The following is a description of a gene set: mouse primary BMDCs were stimulated with tlr ligands and gene expression changes were profiled on Affymetrix arrays Human Gene Set: GSE17721_POLYIC_VS_CPG_6H_BMDC_UP species: Homo sapiens Genes up-regulated in comparison of dendritic cells (DC) stimulated with poly(I:C) (TLR3 agonist) at 6 h versus DC cells stimulated with CpG DNA (TLR9 agonist) at 6 h. from publication Amit I, Garber M, Chevrier N, Leite AP, Donner Y, Eisenhaure T, Guttman M, Grenier JK, Li W, Zuk O, Schubert LA, Birditt B, Shay T, Goren A, Zhang X, Smith Z, Deering R, McDonald RC, Cabili M, Bernstein BE, Rinn JL, Meissner A, Root DE, Hacohen N, Regev A (PMID 19729616), and this is the list of marker genes: CEP350, MTARC2, ASB7, AHCYL2, MVP, FUNDC1, OTULINL, RNF128, SEC22A, DNAJC12, BRINP1, TALDO1, BCL2L14, XRN1, WDFY1, FRYL, N4BP3, INA (NCBI Gene Id 9118), POLB, DNAJC8, CWC22, NUP42, UCK2, HMBS, RAB3IP, RPS16, CBX2, GNA13, KIF1B, INSIG2, MEF2C, HOMER1, SPEN, RGS14, MOCOS, EPB41, CNTROB, ATP8A1, MTMR4, PLEKHA2, SNAPIN, LMNA, CUL4B, OAS2, TNRC6A, MCM7, STXBP1, RRAGC, MYOF, FAM53C, SLC25A3, MIA2 (MIA SH3 domain ER export factor 2), TBCE, RPL12, MCM6, ARGLU1, PHKB (NCBI Gene Id 5257), BRWD3, LRRC61, TIMM8A, PIP5K1C, MORC3, COX7A2L (NCBI Gene Id 9167), RAB12, SDF2, CTDSP2, ATXN7, DNMT3A, SESN3, GPSM2, SRRD, SPATA19, CORO1C, VGLL4 (vestigial like family member 4), TMEM268, MED11, CHIC2, FGR, LRRC40, ECE2, FLI1, CDKN1B, RAP2C, ARHGEF7, HERPUD2, LEF1, SERINC3, HSDL2, TOB1, PARP8, HTR3A, MAGI3, ASF1A, NECTIN4, SPSB1, COMT, BLTP3B (NCBI Gene Id 23074), DAPP1, KDF1, ITCH, HAUS4, SUN2, REEP5, PLCG2, CDA, RP2 (NCBI Gene Id 6102), TMEM37, PALS2, STOM, LHX2 (NCBI Gene Id 9355), LAMTOR1, TSPAN14, MAFK, RFC1, PTCH2, XPO1, RIN2, UGDH, PLEKHF2, SYNJ2BP, METTL8, CD2AP, BRDT, FANCA, PSMG1, SEMA3F, MIA3, KDM5B, PHLDB1, TREX1, PNRC1, SPHK1, USP15, ULK1, GRN, IRAK4, CSNK1D, UQCRC2, MRC1, CLIP1, JRK, BIRC2, MTBP, ACIN1 (NCBI Gene Id 22985), NUP93, RASAL2, CTSC, EI24, BCL9, NFIL3, ZC3H18, PGLYRP1, MAP2K3, FCGR1A (NCBI Gene Id 50698), NAGA, ECHDC1, ANKIB1, AVL9 (NCBI Gene Id 23080), PTCH1, AFTPH, PSIP1, ACVR1, BBS9, CHST15, AAK1, ACADM, RREB1, SP7, SNX2, CASP8 (caspase 8), EN1, BMPR1A, SCAMP2, HEXB, MATK, MRPL39, INPP1, MTHFR, ZFP36L1, PAXBP1, SLC52A3, ANKRD44, MR1, NACC1, U2SURP, TSPAN8, GMNN, CAMK2G, HES6, STK24 (NCBI Gene Id 8428), ATP9A, SUCLA2, PLPP2 (NCBI Gene Id 8612), NRDE2, FRRS1, SPINT2, MKNK1, HR (HR lysine demethylase and nuclear receptor corepressor), SUDS3, IL10RA